The following is a description of a gene set: studied in species Homo sapiens A developmental defect resulting in abnormal closure, or atresia of the tubular structure of the jejunum. Human Gene Set: HP_JEJUNAL_ATRESIA Jejunal atresia, and this is the list of marker genes: MYCN (NCBI Gene Id 53360), MIR17HG (NCBI Gene Id 407975), SLC25A12, TTC7A, RFX6, AP1S1, ZNF699, PPP1R12A, CENPF